The following is a description of a gene set: Human Gene Set: GOBP_NEGATIVE_REGULATION_OF_PLASMINOGEN_ACTIVATION Any process that decreases the rate, frequency or extent of plasminogen activation. Plasminogen activation is the process in which plasminogen is processed to plasmin. studied in species Homo sapiens, and this is the list of marker genes: SERPINE1, THBS1 (thrombospondin 1), PLAU, CTSZ, SERPINE2, SERPINF2, PLAT